The following is a description of a gene set: Binding to a primary microRNA (pri-miRNA) transcript, an RNA molecule that is processed into a short hairpin-shaped structure called a pre-miRNA and finally into a functional miRNA. Both double-stranded and single-stranded regions of a pri-miRNA are required for binding. studied in species Mus musculus Mouse Gene Set: GOMF_PRIMARY_MIRNA_BINDING, and this is the list of marker genes: Dgcr8, Ddx3x (DEAD box helicase 3, X-linked), Smad1, Myhas, Pus10, Drosha, Stat3, Ezh2, Ddx5, Srf, Srsf3